Given this list of marker genes CCT2, CCT4, CCT8L1P, TCP1, CCT6B, CCT7, CCT5, CCT8L2, CCT8, CCT3, CCT6A, here is a description of the gene set: species: Homo sapiens Human Gene Set: GOCC_CHAPERONIN_CONTAINING_T_COMPLEX A multisubunit ring-shaped complex that mediates protein folding in the cytosol without a cofactor.